The following is a description of a gene set: from publication Favila MA, Geraci NS, Zeng E, Harker B, Condon D, Cotton RN, Jayakumar A, Tripathi V, McDowell MA (PMID 24808365) Human Gene Set: GSE42088_UNINF_VS_LEISHMANIA_INF_DC_8H_DN Leishmania major infected human dendritic cells (DCs) exhibit a marked induction of IL-12 ultimately promoting a robust Th1-mediated response associated with parasite killing and protective immunity. In this study, we utilized Affymetrix Genechips to globally assess the host cell genes and pathways associated with L. major infection during early infection (2, 4, 8, and 24 hrs) in human myeloid-derived DCs. Bioinformatic analyses of the hybridized microarray chips identified genes, represented by 848 unique probe sets, which, when compared to uninfected samples were observed to be significantly differentially expressed by one-way ANOVA. Altogether, the data provide a genome-wide perspective on the transcriptional influences Leishmania species exert within human DCs during early infection, and provides a platform for further investigations toward functionally characterizing candidate genes of importance to the IL-12 based immune response to infections. In the current study, we further investigate the L. major infected DC transcriptional during early time points after infection via microarray analysis. species: Homo sapiens Genes down-regulated in dendritic cells: untreated versus 8h after infection of Leishmania major., and this is the list of marker genes: PFKFB4, AMOT, MEPE, KDM4A, SNCAIP, KIF15, TRAM2, AMMECR1, TRIL, ADPGK (NCBI Gene Id 83440), RPE, GPATCH2, HAP1, SSX3, PSAP, ZNF93, SOD3, LIMD1, GRM7, MTMR12, CHAF1A, ALOX5, F11R, ACKR3, NBEA, PKNOX2 (NCBI Gene Id 63876), NPIPB15, MACROH2A1, UNC5C, AOC2, GPR162, ETAA1, SLC19A4P, PEAK1, NINL, MED14OS, ADGRG2, NAA16, PARD6B, SLC25A31, TMLHE, RRAGB, ABCD2, LRP2BP, MTUS1, ARSB, HACD1, SERPINF1 (serpin family F member 1), PHC1, NPY2R (NCBI Gene Id 4887), PLD2, BMPR1B, RHOT1, DEFA6 (NCBI Gene Id 1671), CD207, RARRES2, CAMK2G, IL10RA, SNTB2, IFNGR1, ROBO4, LRP1B, CDK20, VPREB3, FAM53C, NSD3, SLCO4C1, MCM10, PLS1, APBB1, GRAMD1C, PDE6A, LDHAL6B, ZNF391, PCLO, BMP15, SLC4A10, ZFYVE26, PRKN, HPS1, KRT4, PCYOX1, ZNF41, POLA1, PAK6, CLCN3, PSME3IP1, RGS3, ZNF180, RGS17, KCNMB3, ZNF253 (NCBI Gene Id 56242), SPO11, LAMA1, CREB5, GPX1, DZANK1, HIF3A, RAB33B, IRF6, IL3, MAGEA4, CCN2, ZNF682, GPR63, ABCC2, ERBB3, CEP164, TACSTD2, SLC25A14, SLC9A3, PRRG3, PCDHGC3, DST, SCRN3, NPC2, MEIS2, UEVLD, CRYBG3, VPS52, TRDMT1, CUEDC1, REPIN1, DYM, MAPT, VAT1, PARP2, MECOM, YLPM1 (YLP motif containing 1), ANKRD26, PTH, ZKSCAN7, CIITA (class II major histocompatibility complex transactivator), CEP41, KCNJ6, H3C3, HS2ST1, FBXO22, DHTKD1, ATP1A3, IL36A, BAIAP2, ARL15, NEUROD1, B3GALT1, GABRA3, GPHN, PIP5K1B, DGKE, IL33, NFIC, ASB9, ST18, IFNA21, NEB, NUAK1, NAV3, AIRE, SYT1, GULP1, ZNF304, SYNPO2L, CYP2A7, FHOD3, SLFN12, NDUFAF5, SHTN1, P2RX2, SLC30A6, PECAM1, NSUN7, DYNC2LI1, WNT7A, COL10A1, FN1, NXPE3, NBAS, PSG5, CDH6, TRIP13, MAPK9, KIR3DX1, USP6 (ubiquitin specific peptidase 6), TMEM19, NTSR1, PART1, CACNA1G, SEPTIN11 (NCBI Gene Id 55752), ZNF43, ATP9B, MAGEC3, TPP1, PYY, WWTR1, CSN1S1, RUSC1, TNFRSF11A